The following is a description of a gene set: studied in species Homo sapiens Human Gene Set: GSE14769_UNSTIM_VS_80MIN_LPS_BMDM_DN from publication Litvak V, Ramsey SA, Rust AG, Zak DE, Kennedy KA, Lampano AE, Nykter M, Shmulevich I, Aderem A (PMID 19270711) Genes down-regulated in comparison of unstimulated macrophage cells versus macrophage cells stimulated with LPS (TLR4 agonist) for 80 min. The innate immune system is a two-edged sword; it is absolutely required for host defense against infection, but if left uncontrolled can trigger a plethora of inflammatory diseases. Here we used systems biology approaches to predict and validate a gene regulatory network involving a dynamic interplay between the transcription factors NF-κB, C/EBPδ, and ATF3 that controls inflammatory responses. We mathematically modeled transcriptional regulation of Il6 and Cebpd genes and experimentally validated the prediction that the combination of an initiator (NF-κB), an amplifier (C/EBPδ) and an attenuator (ATF3) forms a regulatory circuit that discriminates between transient and persistent Toll-like receptor 4-induced signals. Our results suggest a mechanism that enables the innate immune system to detect the duration of infection and to respond appropriately., and this is the list of marker genes: RAPGEF2, CDK17, JMJD1C, SPRYD7, HERPUD1, TRIM13, SQSTM1, PSMB11, PTCH1, STIL, ISG15, MYEF2, GADD45B, USP18, ANKRD33B, TREX1, PLEK, LIMA1, PTGER4, RABGEF1, EHD1, FOS, CFLAR, SRGN, TRAF1, CCDC71L, RBM39, TMEM171, GBP2, DNAJA2, FILIP1L, SELE, RORB, DUSP14, IL1RN, NAMPT, CALB2, IRF1, NUP54 (nucleoporin 54), BTG1, CH25H, EXOC3L4, REL, DUSP4, RASGEF1B, IRGQ, EBI3, GDF15, SDE2, MAFF, GTF2B, ZBTB11, ARL5B, GPR84, SOD2, ARIH2, DUSP1, ZNF622, CSRNP1, GJA1, ID2, C11orf96, ADAMTS1, KLF7, TNFSF14, EGR2, CCNL1 (cyclin L1), CAV1, HK2, IL10RA, NUPR1, ZNF81, BCL2A1, MAP3K8, PLAUR, RAB20, BCL2L11, RIPK2, TMEM185A, NFIL3 (nuclear factor, interleukin 3 regulated), BMP2, ABL2 (NCBI Gene Id 27), SUCO, MALT1, DIO2, GPR19, OSM, FAM133B, FLRT3, SLFN12L, CD83, TASL, MYC, HBEGF, GPBP1, AEBP2, TGIF1, HNRNPLL, ATF3, USP16, RAB12, ZC3H12A, OSGIN2, BIRC3, SGMS1, CITED2, PHLDA1, NSMCE1-DT, NDEL1, IL23A, SBDS, FAM72A (NCBI Gene Id 729533), WSB1, SLC38A2, CCL5, NOCT, SLC15A3, FGD6, ICAM1, CXCL1, RNF2, HSPA1B, BTG2, CCL13, PNRC1, KCTD12, SERPINE1, NFKBIE, MMP13, IFNB1, NFKBID, IL10, FRMD6, ACOD1 (NCBI Gene Id 730803), KLF6, SRFBP1, NABP1, MTMR14, TIPARP, SLAMF7, SASH1, KIAA0586 (NCBI Gene Id 9786), TNFAIP2, COQ10B, ITGAV, TLE4, IER5, ETF1, IER2, IL1B, PLSCR1, CCN1, HILPDA, DUSP5, PDGFB (platelet derived growth factor subunit B), FEM1C, RGS1, BCL10, ZC3H12C, TNFSF9, GFPT1, MCL1, SIAH2 (NCBI Gene Id 6478), SPRED1, TMEM108, EXTL2, RNF19B, ABTB2, STX11, CD69, ZRSR2, ARID5A, CDC42EP2, SLC25A25, TLR2, PIM3, MED21, ETV3 (ETS variant transcription factor 3), CCRL2 (C-C motif chemokine receptor like 2), FOSL2, KDM6B, FBXO30, CLEC4E, SLAIN2, C9orf72, ID3, CCL4, FABP4, HSPA1A, ZFAND5, TGM2, CEBPB, VPS37C, NFAT5, DUSP8, HELZ2, AGT, BCL6, ZNF800